Given this list of marker genes Arg1, Slc7a3 (NCBI Gene Id 11989), Slc7a1, Agt, Slc47a1, Slc22a2, Arg2, Slc7a2, here is a description of the gene set: Mouse Gene Set: GOBP_L_ARGININE_IMPORT_ACROSS_PLASMA_MEMBRANE The directed movement of L-arginine from outside of a cell, across the plasma membrane and into the cytosol. species: Mus musculus